Given this list of marker genes MC3R, ATP1A1, SPX, SLC9B2, SCN7A, UMOD, TMPRSS3, EDN1, SCNN1D, SLC1A3, DRD2, ATP4B, FXYD2, ATP12A, CYP4A11, SLC9A1, EDNRA, SCNN1G, ATP4A, SLC12A1, ATP1B3, COMT, EXT1, EDNRB, IL1A, CORIN, SCNN1B, ATP1A3, CYP11B2, ATP1A2, CYP4F12, UPK3A, ATP1A4, MLLT6, SLC12A2, SCNN1A, SLC8A1, NPR1, CYP4F2, SLC12A3, AGT, ATP1B2, AGTR1, ATP6V1B1, EXT2, ATP1B1, NPPB, here is a description of the gene set: Any process involved in the maintenance of an internal steady state of sodium ions within an organism or cell. Human Gene Set: GOBP_SODIUM_ION_HOMEOSTASIS studied in species Homo sapiens